Given this list of marker genes ABCC5, NHERF1, SLC25A39, GJA1, MGST1, ABCC4, SLC7A11, SLC25A40, SLC13A3, ABCC1, here is a description of the gene set: Human Gene Set: GOBP_GLUTATHIONE_TRANSPORT studied in species Homo sapiens The directed movement of glutathione, the tripeptide glutamylcysteinylglycine, into, out of or within a cell, or between cells, by means of some agent such as a transporter or pore.